Given this list of marker genes TUBB2B, CHKA, ABCA2, PHLPP2, VIRMA, F3, ZMIZ1, RETSAT, PML, COIL, CNNM3, SLC27A1, TCF4, FIRRE, THEMIS2, RUNDC3A, MBD4, EIF3K, STOML1, ALYREF, SETD6, ODC1 (NCBI Gene Id 4953), HAUS4, ST3GAL2, RAMP1, RRP7A, STARD10, RGS7BP, UGDH, FECH, ST6GALNAC4, PVT1, MON1A, RAB5B, EVX1, BAMBI, PHAX, SYT11, AKR1B1, PCGF5, ELOVL6, EIF2B2, RNF187, SMARCC2, SERTM1, PPP1R27, SYT16, ALPK2, WWP2, DHX32, SLC26A10P, PCED1B, CAPN15, TTYH2, CASC3 (NCBI Gene Id 22794), NABP2, SMIM5, BATF3, IL12RB2, OLA1, ERI3, GLO1, C16orf54, ERCC4, CUL2, RTCB, TRIM13, TRIM11, AKAP8, FAM53C, OSTF1, DICER1, NSMCE4A, MYO3A, NSUN4, SLC25A4, CDKAL1, TBC1D19, PALS2, RGS12, MRPL19, DEF8, ZNF23, TIMM23, CREBBP (NCBI Gene Id 1387), GDPD5, UHRF1, KAT2A, BAZ2B, HBEGF, TBC1D14, P4HTM, MKNK2, PITPNC1, PRICKLE1, SLITRK2, BHLHE40, ZNF236, TCF3, RBM22, RPS19, PPFIA1, SH2D1A, PRCD, PCBP4, VPS39, ILRUN, TP53I13, SMYD2, CXCL11, ZBTB14, FAM76A, SSU72, RPS3, RPL39, EVL, CSNK1G2, LRIG1, CSAD, RNMT, TSPAN13 (NCBI Gene Id 27075), NIPBL, DRD2, RNF14, HEG1 (NCBI Gene Id 57493), SLITRK1, TRAF3IP2, FRA10AC1, RAD1, DDX46, N6AMT1, ARHGAP1, CYTIP, RNF125, ABCA7 (ATP binding cassette subfamily A member 7), DDT, GTF3A, MEAK7, PTCRA, ERI1, CISD1, CRISPLD2 (cysteine rich secretory protein LCCL domain containing 2), APPL2, SMC6, NF2, MFHAS1, PDE3B, PMS2, GPR18, ZBTB44, PITPNA, FAP, CCT2, B4GALNT1, PACS2, RING1, FRMD6, RAB23, RIC8B, MARVELD1, NDUFA10, FAM91A1, CYFIP2, PTHLH, SMAD7, NCBP2AS2, IFT43, GLRA3, GRK2, MTA3 (metastasis associated 1 family member 3), ZC4H2, PHF21A, DNMT3L, TRIM45, MYC, RBM12, C1orf21, KIF2A, WDR38, RCN2 (NCBI Gene Id 5955), EEFSEC, TMEM120B (transmembrane protein 120B), R3HDM1, RORC, DLGAP4, PIP4P2 (phosphatidylinositol-4,5-bisphosphate 4-phosphatase 2), PARVB, GNG2, KCTD17, GPR152, GTF2I, CAMSAP2, DDX42, LTA, LEMD3, TNRC6B, CRLF3, MOB2, CLOCK, RPL41, here is a description of the gene set: species: Homo sapiens from publication Nurieva RI, Chung Y, Hwang D, Yang XO, Kang HS, Ma L, Wang YH, Watowich SS, Jetten AM, Tian Q, Dong C (PMID 18599325) Human Gene Set: GSE11924_TH2_VS_TH17_CD4_TCELL_DN Genes down-regulated in comparison of Th2 cells versus Th17 cells. After activation, CD4+ helper T (Th) cells differentiate into distinct effector subsets. Although chemokine (C-X-C motif) receptor 5-expressing T follicular helper (Tfh) cells are important in humoral immunity, their developmental regulation is unclear. Here we show that Tfh cells had a distinct gene expression profile and developed in vivo independently of the Th1 or Th2 cell lineages. Tfh cell generation was regulated by ICOS ligand (ICOSL) expressed on B cells and was dependent on interleukin-21 (IL-21), IL-6, and signal transducer and activator of transcription 3. However, unlike Th17 cells, differentiation of Tfh cells did not require transforming growth factor b (TGF-b) or Th17-specific orphan nuclear receptors RORa and RORg in vivo. Finally, naive T cells activated in vitro in the presence of IL-21 but not TGF-b signaling preferentially acquired Tfh gene expression and promoted germinal-center reactions in vivo. This study thus demonstrates that Tfh is a distinct Th cell lineage.